Given this list of marker genes Ercc3, Mbd3, Polr1c, Taf1d, Mta1, Rbbp4, Gtf2h4, Polr1g, Ercc6, Polr1h, Polr2f, Mta2, Polr2k, Rbbp7, Ercc2, Polr2e, Polr2l, Gtf2h2, Polr1e, Tbp, Ccnh, here is a description of the gene set: studied in species Mus musculus Reactome Pathway: RNA Polymerase I Transcription Initiation part of: RNA Polymerase I Promoter Clearance electronically inferred by orthology from the curated human pathway This event has been computationally inferred from an event that has been demonstrated in another species.<p>The inference is based on the homology mapping from PANTHER. Briefly, reactions for which all involved PhysicalEntities (in input, output and catalyst) have a mapped orthologue/paralogue (for complexes at least 75% of components must have a mapping) are inferred to the other species.